The following is a description of a gene set: studied in species Homo sapiens TREM-1 is an orphan immunoreceptor expressed on monocytes, macrophages, and neutrophils. TREM-1 associates with and signals via the adapter protein DAP12/TYROBP, which contains an immunoreceptor tyrosine-based activation motif (ITAM). TREM-1 activation by receptor cross-linking is pro-inflammatory, and can amplify cellular responses to Toll-like receptor (TLR) ligands such as bacterial lipopolysaccharide (LPS). To investigate the cellular consequences of TREM-1 activation, we have characterized global gene expression changes in human monocytes in response to TREM-1 cross-linking in comparison to and combined with LPS. Both TREM-1 activation and LPS up-regulate chemokines, cytokines, matrix metalloproteases, and PTGS/COX2, consistent with a core inflammatory response. However, other immunomodulatory factors are selectively induced, including SPP1 and CSF1 (i.e., M-CSF) by TREM-1 activation and IL-23 and CSF3 (i.e., G-CSF) by LPS. Additionally, cross-talk between TREM-1 activation and LPS occurs on multiple levels. While synergy in GM-CSF protein production is reflected in commensurate mRNA abundance, comparable synergy in IL-1b protein production is not. TREM-1 activation also attenuates the induction of some LPS target genes, including those that encode IL-12 cytokine family subunits. Whereas positive TREM-1 outputs are abolished by the PI3K inhibitor wortmannin, this attenuation is largely PI3K-independent. These experiments provide a detailed analysis of the cellular consequences of TREM-1 activation, and highlight some of the complexity in signal integration between ITAM- and TLR-mediated signaling. Genes down-regulated in comparison of monocytes treated with anti-TREM1 versus monocytes treated with anti-TREM1 and 5000 ng/ml LPS (TLR4 agonist). Human Gene Set: GSE9988_ANTI_TREM1_VS_ANTI_TREM1_AND_LPS_MONOCYTE_DN from publication Dower K, Ellis DK, Saraf K, Jelinsky SA, Lin LL (PMID 18292579), and this is the list of marker genes: FRMD7, PDSS1, SLC1A3, PMAIP1, MFSD2A, LINC01465, CXCL3, TNFAIP6, S100A7, GIMAP5 (GTPase, IMAP family member 5), DLGAP1-AS2, TPD52, NOCT, PHF19, LINC00528, PLEKHF2, DUSP2, MMP10, MAP3K20-AS1, KCNJ2, TJP2, MSANTD3, TNFRSF9, CSF2, CYB5D1, ETS2, ARHGEF2, CCL20 (NCBI Gene Id 6364), LINC01138, RCSD1, CCSER2, RPGR, IL6ST-DT, RNF144B, BTG3, ZFX, PPP1R15A, LINC00265, TRAF1, MAP3K8, SNX10, RAP2C, CDK1, PTGS2, TANK, TNFAIP8, ATF7IP2, PIM3, ZFP36, NAF1, NEK2-DT, NBN, OSM, ZC3H12A, NLRP3, CT75, ANO5, IL18, IRAK2, FH, PTP4A1, AQP9, NFKBIZ, KLF6, CLEC2D, ICAM4, LINC01093, NEMP1, SFR1, ARL5B, ACSL1, DENND4A, RDH10, CCR7, SYNPO2, NINJ1, SOCS3, SESTD1, TBC1D9, ELOVL7, ERN1, PRPF3, PSMD5, SLC11A2, IL10, C12orf50, MIR3142HG, C11orf96, F8, GADD45A, RBBP8, IL6, ACVR2A, PFKFB3, CCL4, GJB2, STK26, E2F7, KCNJ2-AS1, PELI1, DYRK3, CD83, ADORA2A-AS1, NIPA1, IFNB1, PLK3, TNIP3, NTRK2, STAT5A, HCAR3, WTAP, CSRNP1, SOD2 (NCBI Gene Id 79099), ACOD1, G0S2, PPM1K, TP53BP2, SUSD6, PTX3, SLC2A6, ZFC3H1, EHD1, GCH1, CFHR3, IL23A, MIR3945HG, TTC32, CCRL2, DNER, BIRC3, CLCF1, GPR84, IFNGR2 (NCBI Gene Id 3460), IER3, IL1B, RHOF, GBP1, LINC00158, AFDN-DT, DENND5A, PPP1R15B, DCUN1D3, YRDC, ICAM1, SAV1, GPR132, RIPK2, DRAM1, MSH6, RBM17, SERPINB2, CFLAR, ADORA2A, TNF, ENSG00000284634, IL36G, PLEK, SDC4, TNFAIP2, ATP2B1-AS1, HNRNPC, ADAMDEC1, PLA1A, CSF3 (colony stimulating factor 3), TEX14, BCL2A1, PLAUR, ID2, CLIC4 (NCBI Gene Id 25932), FLT1, RHOH (NCBI Gene Id 399), RNF19B, SIAH2, CD274, CLEC4E, HIVEP1, MIR155HG, TSLP, LINC00299, CXCL8, KDM7A-DT, ITGB8, ZBTB10, CXCL2, RAPGEF2, ZC3H12C, NFKBIA, ZC3HAV1, F3, KMO, TNFAIP3 (NCBI Gene Id 7128), IL1A, TIFA, IL2RA, MAP3K4, SPECC1L